The following is a description of a gene set: Prolonged QTc interval species: Homo sapiens A longer than normal interval (corrected for heart rate) between the Q and T waves in the heart's cycle. Prolonged QTc can cause premature action potentials during late phase depolarizations thereby leading to ventricular arrhythmias and ventricular fibrillations. Human Gene Set: HP_PROLONGED_QTC_INTERVAL, and this is the list of marker genes: FBN1, KCNQ1, KCNE2, KCNJ2, ADAMTS17, KCNA5, TNNI3K, MECP2, CAV3 (NCBI Gene Id 859), TANGO2, LTBP2, KCNH2, AKAP9, CALM2, TBX5, ANK2, KCNE1, SVIL, FLNC, SNTA1, ADAMTS10, CALM1, ALG10B, CALM3, NOS1AP, TECRL, KCNJ5, SCN10A, SCN5A, TRDN, HCN4, SCN4B, CACNA1C